The following is a description of a gene set: species: Mus musculus Mouse Gene Set: GOBP_GLOMERULAR_ENDOTHELIUM_DEVELOPMENT The process whose specific outcome is the progression of the glomerular endothelium over time, from its formation to the mature structure. The glomerular endothelium is an epithelial tissue that covers the internal surfaces of the glomerulus., and this is the list of marker genes: Pdgfb, Ednra, Edn1, Foxc2, Cd34